The following is a description of a gene set: This event has been computationally inferred from an event that has been demonstrated in another species.<p>The inference is based on the homology mapping from PANTHER. Briefly, reactions for which all involved PhysicalEntities (in input, output and catalyst) have a mapped orthologue/paralogue (for complexes at least 75% of components must have a mapping) are inferred to the other species. electronically inferred by orthology from the curated human pathway studied in species Mus musculus Reactome Pathway: Metabolism, and this is the list of marker genes: Cyp2a12, Chst14, Arnt2, Nup210, Tk1, Fdxr, Psmd13, Cers1, Uckl1, Uck1, Uqcrfs1, Tm7sf2, Psmc6, Akr1d1, Xylt1, Glb1l3, Cyp4a29, Pld6, Ndufb8, Rrm1, Rpia, Eci2, Ldhc, Nmrk1, Hmmr, Mtmr1, B4galnt2, Prkar2b, Psap, Nt5c1b, Ndufa12, Plcd3, Ces2h, Kpnb1, Cyp4a12a, Tspoap1, Gchfr, Tpk1, Degs2, Hykk, Ndufa10, Ranbp9 (RAN binding protein 9), Vkorc1, Pla2g2a, Slc44a3, B3galt2, Ugt1a9, Gpx4, Gpx2, Hexa, Nat3, Nup58, Hadha, Tmem126b, Pik3r5, Flad1, Cyp4f39, Ltc4s, mt-Nd6, Psmd12, Pgam2, Fah, Gls2, Ndufa5, Slc25a11, Lclat1, Gng11, Dct, Cyp1a1, Sdhb, Ndufs8, Gng7, Pudp, Adprm, Vdr, B3gat1, Arv1 (ARV1 homolog, fatty acid homeostasis modulator), Gng4, Impdh2, Qprt, Cyp26a1, Slc25a19, Amacr, Cox4i1, Akr1b1, Mtmr3, Sdhaf3, Acox3, Pgls, Bckdhb, Ugt2b1, B3gnt3, Galns, Nmral1, Mtmr2, Psmb7, Otc, Kcnb1, Psmc1, Uroc1, Ppip5k2, Xdh, Gstp1, Ormdl2, Psma2, Fdx1, Pycr2, Mfsd2a, Ndufb10, Abcd4, Acss3, Plch1, Kmo, Glyctk, Pla2g3, Gid4, Ndufv2, Itpka, Arsi, Arg1, Fabp6, Pip4p1, Ndst3, Sephs2, Sdc1, Cox4i2, Gng10, D2hgdh, Acad10, Hgd, Apoc2, Acot4, Pts, Adcy5, Acsm1, Hk3, Pik3c2b, Cox7a2l, Nosip, Ndufa7, Agpat3, Fut1, Cspg5, Cox17, Mthfr, Alas2, Ndc1, Pnp, Bgn, Slc37a4, Plpp6, Slc25a10, Taldo1, Sts, Cacna1a, Uqcr10, Hal, Chst12, Ado, Ldhal6b, Tpi1, Cox14, Acot7, Ndufb3, Cyp2c65, Ugt2b36, B3galt5, Psmd7, Hao1, Dao (D-amino acid oxidase), Nme2, Ubiad1, Slc25a42, Ggt6, Cyp1a2, Osbpl1a (NCBI Gene Id 64291), Cox5a, Cox6c, Ndufaf4, Cidec, B4galt6, Cox8a, Ffar1 (NCBI Gene Id 233081), Slc25a14, Grhpr, Entpd5, Asrgl1, Srd5a1, Dhcr7, Glb1l2, Azin2, Dcn, Tpo, B3gat2, Atp5mc1, Acsf2, Sptssb, Carnmt1, Gstm1, Nadsyn1, Ndufa4, Nup155, Acbd6 (NCBI Gene Id 72482), Fitm1 (NCBI Gene Id 68680), Ppip5k1, Sirt4, Abhd10, Alb (NCBI Gene Id 11657), Chac2, Glyatl3, Mdh2, Pon1, Dld, Hpd, Gadl1, Idh2, Nat2, Cox7c, Slc26a11, Gamt, Hsd3b9 (NCBI Gene Id 100043461), Pip4k2c, Cyp8b1, Gngt2, G6pdx, Apoa2, Akr1c20, Ptges2, Faah, Dio2, Dio1, Decr1, Arg2, Prkca, Adss1, Glrx5, Ust, Pnmt, Psma5, Dbi, Tnfaip8l3, St3gal4, Cyp39a1, Scd1 (NCBI Gene Id 20249), Cyp2d22, Aass, Cyp24a1, Galt, Ptpn13, Cyp3a44, Hyal2, Lbr, Chkb, Cga (glycoprotein hormones, alpha subunit), Nt5c1a, Nudt18, Gng8, Fabp2, Suox, Itpk1 (inositol 1,3,4-triphosphate 5/6 kinase), Lipi (NCBI Gene Id 320355), Mogat2, Agmat, Asah2, Cmpk1, Hs3st2, Hpgds, Rab4a, Man2c1, Lpcat4, Ugt1a8, Acad8, Fig4, Ces1d, Ch25h, Gnb5, Man2b2, Acox2, Nt5c2, Upp1, Hsd17b13, Ip6k3, Acot5, Aanat, Lum, Guk1, Cox20, Sdhaf2, Pdp1, Tbl1x, Tnfaip8l1, G6pc1, Tcn2, Spns2, Dctd, Sptlc3, Atp5pf, St8sia5, Sgpl1, Cyp2a4, Gstt2, Rbks, Pip5k1c, mt-Atp8, Thrsp, Ldhb, Car12, Chst2, Gsta3, Aldoa (aldolase A, fructose-bisphosphate), Pgk2, Cidea, Nup205, Carm1, Ugt2b37, Pla2g12a, Higd2a, Ppa1, Gcg, Mtmr9 (NCBI Gene Id 210376), Hmgcll1, Acadsb, Morc2a, Ndufa13, Gpam, Ndufs5, B3galt4, Aacs, Ugt2b35 (NCBI Gene Id 243085), Akr1c18, Ugt3a1, Marcks, Nudt5, Gmps, Fh1, Mmachc, Pi4k2a, Adipor1, Cox7a1, Dpep1, Lhpp, Gstm2, Sumf2, Mtarc1, Neu4, Hsd17b2, Acsm5, Neu3, Chst9, Pik3r2 (phosphoinositide-3-kinase regulatory subunit 2), Atp5f1b, Has1, Ndufs7, Dpyd, Paics, Hsd17b14, Txnrd1, Nudt15, Ido1, Nudt12, Oaz3, Galk1, Alox12, Gstz1, Med1, Ethe1, Slc25a16, Pck2, Oxct2b, Fabp5, Entpd3, Sin3a, Osbpl7, Mboat7, Mtmr6, Abo, Chka, Ubb, Slc22a5, Rimkla, Chsy3, Acadvl, Plce1, Mtmr12, Gale, Btd (NCBI Gene Id 26363), Ndufa2, Akr1b10, Cyp4b1, Cyp3a25, Slc26a1, Slc44a4, Ldha, Dnm2, Alox12b, Mocs3, Idh3g, Gba1 (glucosylceramidase beta 1), Dlat, Inpp5b, Baat, Nudt4, Pcyt1b, Oxct1, Pitpnm2, Dguok, Ppox, Cyp1b1, Cox8c, Bckdk, Ptdss2, Sacm1l, Gapdhs, Ndufaf6, Prkar1b, Got2, Cycs, Aaas, Aspa, Entpd8, Ptdss1, Entpd7, Rbp2, Gpc3, Tpte, Cyp4f18, Sco2, Gc, Carns1, Arsj, Cyp2u1 (NCBI Gene Id 71519), Pik3c3, Pias4, Akr1c14, Hs3st4, Plekha8, Cyp3a41a, Mat1a, Hsd17b1, Stard10, Ugp2, Hsd17b3, Mpst, Idi1, Smpd2, Gm19410, Mthfd2, Fdft1, Mccc2, Pemt, Tst, Pld2, Hexb (hexosaminidase B), Mid1ip1, Slc36a4, Cox6a1, Dgat2l6, Slc25a21, Aoc2, Lrp12, Akr1c21, Gngt1, Neu1, Tymp, Bcat1, Ugt2a1, Akr1c6, Gpc2, Naxe, Sdc3, Psma4, Pla2g4d, L2hgdh, Ndst2, Psmc4, Pcyt1a, Cyp4f15, Gpihbp1 (GPI-anchored HDL-binding protein 1), St6galnac6, Cyp3a57, Sds, Mtmr14, Nup133, Cyp2c55, Cyp2f2, Car9, Duoxa1 (dual oxidase maturation factor 1), Hsd3b8, Cyc1, Awat1, Cyp4v3, Gch1, Pla2g2d, Mri1, Stard3nl, Pitpnb, Csgalnact1, Ak8, Mocos, Gstt1, Ormdl3, Ptgis, Elovl2, Pla2g2e, Stard3, Sgpp2, Gk2, Adsl, Ckb, Slc5a6, Vnn1, Bpnt1, Nudt9, Abcb11, Car6, Nsdhl, Slc19a1 (NCBI Gene Id 20509), Slc25a22, Dbh, Cds1, Kynu, Acan, Nqo2, Fahd1, Gpt, Gpx1, Adal, Cyp11b2 (NCBI Gene Id 13072), Cyb5b, Slc27a5, Ucp1, Sgpp1, Cyp3a16 (NCBI Gene Id 13114), Mcee, Cox18, Rida, Duoxa2, Inpp5e, Hs6st1, Sardh, Ddc, Eci1, Chac1, Nqo1, Pnlip, Pgm2l1, Acbd7, Tmem177, Iscu, Hyal5, Ptgds (NCBI Gene Id 19215), Ctps1, Pyurf, Acsl4 (acyl-CoA synthetase long-chain family member 4), Hyal1, Man2b1 (mannosidase 2, alpha B1), Gda, Vdac1, Plpp1, Serpina6, Mboat2, Atp5po, Hilpda, Slc35b2, Gnmt, Pla2g4f, Cd36, Csnk2b, Cd38 (CD38 antigen), Pla2g2f, Prkaca, Cyp3a11, Hsd17b11, Coq10a, Agpat1, Gsta2, Cblif, Aldh1b1, Naprt, Mtap, Ptgs2, Pik3cb, Hsd17b8, Pdha1, Tyms, Hkdc1, Psmc2, Cyp3a41b, Alox8, Khk, Arsa, Ggt1, Pdzd11, Dhcr24, Tbxas1, Abcg2, Cda, Zdhhc21, Seh1l, Crym (NCBI Gene Id 12971), Lrp1, Pfkfb1, Dmgdh, Dpep2, Srd5a2, Pank3, Gstm5, Arsg, Cox6a2, B4galt7, Tyr, Acaa1b, Rbp1, Nr1h4, Hacd4, Hsd3b4, Nmnat3, Ugt2a2, Hmox2, Blvrb, Uqcr11, Acsm2, Slc25a32, Odc1, Car13, Ocrl, Aloxe3, Abcc3, Oca2, Pdpr, Pgam5, Slc6a7, Isca1, Ugt2b38, Atp5mk, Nme3, Lrp8, Psma1, Gng3, Cyp26b1 (cytochrome P450, family 26, subfamily b, polypeptide 1), Gbe1, Pi4ka, Kcnj11, Mtmr4, Ttpa, Cmbl (carboxymethylenebutenolidase homolog), Pnp2, Bco2, Higd1c, Elovl5, Lyrm4, Akr1b7, Oat, Sult1b1, Psmc5, Pon3, Ggt7, Aadat, Dse, Coq7, Ido2, Neu2, Shpk, Plpp2, Acbd5, Srebf2, Tkt, Ugt2a3, Cyp2c66, Glb1l, Fa2h, Chst5, Pnpla6 (patatin-like phospholipase domain containing 6), Psma3, Slc22a13, Isyna1, Mecr, Hacd2, Ephx2, Apoe, Gba2, Aldh2, Th, Ran, Gng5, Ext1, Pygm, Cyp7a1, Helz2, Gsta13, Cyp4a10, Podxl2, Tspo, Oaz1, Rbp4, Eno4, Fut4, Hs3st3b1, Pfkl, Pcyt2, Acot3, Ggt5, Ucp3, Sult6b1, Duox1, Cyp3a13, Dgat2, Oxct2a (3-oxoacid CoA transferase 2A), Ugdh, Slc3a2, Sptlc2, Uros, Nudt10, Chsy1, Ndufa9, Nme1, Hibadh, Bco1, Ucp2, Nat1, Iyd, Ak7, Sgsh, Plcb3, Phykpl, Ehhadh, Txn1, Slc37a2, Cad, Upb1, Ces3a (carboxylesterase 3A), Nudt11, Tmem86b, Tpmt, Slc35d1, Ndufb9, Pnpla3, Slc51b, Acy3, Tecrl, Entpd2, Pla2g6, Pomc, Nup93, Slc10a2, Trap1, Cpne6, Nup54, Hmgcs1, Csgalnact2, Adipor2, Urod, Gart, Mtrr, Ckmt1, Pgp, Aldh9a1, Cyp4a30b, Tkfc, Acot8, Acsf3, Apoa4, Coq2, Nudt16, Aspg, Pycr1, Ces3b, Ndufs3, Eno3, Inpp5j, Ugt1a5 (UDP glucuronosyltransferase 1 family, polypeptide A5), Slc44a2, Slc25a2, Adipoq, Fmo1, Osbpl5, B3galnt1, Elovl7, Acp5, Pcbd1, Bcat2, Akr1c13, Ckmt2, Cyp2e1, Psma7, Mlycd, Mmab, Coa5, Phkg2, Abcd1, Slc2a1, Lalba, Cacna2d2, Slc9a1, Amt, Gcgr, Hs6st2, Plbd1, Nt5c, Acsm4, Plch2, Adra2a, Pla2g5, Sqle, Cacnb3, Hccs, Far2 (fatty acyl CoA reductase 2), Psmd1, Hacd1, Nostrin, Cers5, Adra2c, Sumf1, M6pr, Folr2, Pla1a, Naalad2, Gpd1, Naxd, Nubpl (nucleotide binding protein-like), Alox5ap, Tnfaip8, Synj2, Fut9, Bdh2, Ncor2, Adh4, Hoga1, Osbpl2, Psma6, Apoc3 (apolipoprotein C-III), Apob, Gckr, Ugt1a1, Ndufaf7, Psmb5, Fxn, Ippk, Lypla1, Uqcrc2, Psmb6, Hsd3b2, Pdss2, Ptgs1, Hdac3, Ugt1a6a (UDP glucuronosyltransferase 1 family, polypeptide A6A), Aldh3a1, Pnpo, Nudt1, Hsd3b5, Psmc3, Plekha3, Slco1a4, Atp5pd, N6amt1, Ugt1a7c, mt-Nd3, Nudt13, Gpat2, Coasy, Osbp, Rrm2b, Cyp17a1, Apoa1, mt-Cytb, Pdk4, Minpp1, Akr1b8, Pah, Rps27a, Smpd1, Pgm2, Fabp12, Mat2a, Pdk2, Rae1, Ndufaf3, Bdh1, Ada, Pkm, Got1, Xylt2, Osbpl10, Slc5a8, Ip6k2, Ipmk (inositol polyphosphate multikinase), Amdhd1, Ctps2, Prkacb, Vkorc1l1, Alox15, Ak5, Ckm, Gstm6, Car5a, Psmb4, Acot13, Aldob, Dmac2l, Cpt2, Pnpla5, Slc26a2, Slc37a1, Inpp4b, Osbpl6, Psmd6, Serinc4, Gnpda1, Idi2, Gnai1, St3gal5, Nup85, Abhd3, Agmo, Cpt1b, Alpi, Ftcd, Cox10, Ids, Stab2, Gnb2, Omd, Hsd17b4, Cox11, Dck, Sdhaf1, Ecsit, Ak6, Fech, Kera (keratocan), Mgst2, Tat, Slc25a4, Chst13, Galm, Dsel, Gnb3, B3galt6, Car7 (carbonic anhydrase 7), Inpp5a, Rmnd5b, St3gal3, Dlst, Itpkc, Hs6st3, Lpcat2, Hk2, Smpd4, Slc52a3, Chpt1, Elovl3, Trmt112, Mrps36, Calm1, Adh5, Cers4, Abcc2, Crot, Pla2g1b, Acsl6, Pik3c2a, Mtarc2, Kcng2, Glp1r, Cyp4f40, Cav1, Pnpla8, Cerk, Slc45a2, St3gal2, Aco1, Hpse2, Ass1, Plcg2, Sult1c2, Armc8, Slc27a2, Ndufc1, Fbp2, Slc10a1, Atp5mc2, Tyrp1, Cyp51, Srr, Inppl1, Ndufv3, B3gat3, Ddhd2, Nup42, Chst15, Pitpnm3, Hsd11b2, Slc25a13, Oaz2, Fut2, Slc35d2, Cyp19a1 (NCBI Gene Id 13075), Pipox, Nmrk2 (nicotinamide riboside kinase 2), Ncoa1, Acot2 (NCBI Gene Id 171210), Oplah, Mtmr7, Sat1, Tph1, Slc25a18, Agpat4, Cyp46a1, Alad, Gna14, Asns, Lta4h, Cyp2j6, Ndufaf5, Awat2, Aoc3, Ndufb1, Nnmt, G6pc2 (glucose-6-phosphatase, catalytic, 2), Ndufaf1, Decr2, Pfas, Gykl1, Fdx2, Kdsr, G6pc3, Folh1, Aldh3b1 (NCBI Gene Id 67689), Plcz1, Lpl, Gmpr, Ndufs6, Ampd3, Fabp7, Them4, Car4, Pip5k1a, Lrp10, Ppa2, Glud1, Naglu, Dhtkd1, Pla2r1, Hyal4, Arf1, Cyp4a31, Sbf1, Aldh3b2, Gsta1